Given this list of marker genes Arl2 (NCBI Gene Id 80563), Ubb, Abhd17b, Rce1, Icmt, Bcl2l1, Lypla1, Pde6d, Calm1, Fnta, Calm2, Rps27a, Usp17ld, Zdhhc9, Uba52rt, Usp17le, Hras, Abhd17a, Ubc, Usp17la, Uba52 (NCBI Gene Id 56512), Calm3, Golga7, Kras, Usp17lc, Usp17lb, Prkcq, Fntb, Abhd17c, here is a description of the gene set: Mouse Gene Set: REACTOME_RAS_PROCESSING species: Mus musculus RAS processing